The following is a description of a gene set: The process in which the anatomical structures of the face are generated and organized. The face is the ventral division of the head. species: Homo sapiens Human Gene Set: GOBP_FACE_MORPHOGENESIS, and this is the list of marker genes: STRA6, PRICKLE1, SKI, CRISPLD2, TBX1, CLDN5, ANKRD11, LEF1, CRISPLD1, DLX5, PDGFRA, ARID5B, TGFB1, RAB3GAP1, NIPBL, PAX9, SGPL1, DKK1, PTPN11, MYH3, NOG, TGFB2, COL1A1, SCX, ASPH, RRAS, PLEKHA1, EP300, CSRNP1, MSX1, TIPARP, MMP2, TGFB3